The following is a description of a gene set: The cellular developmental process by which a cell establishes the intrinsic character of a cell or tissue region irreversibly committing it to a particular fate. Mouse Gene Set: GOBP_CELL_FATE_COMMITMENT species: Mus musculus, and this is the list of marker genes: Pax3, Wnt10b (NCBI Gene Id 22410), Hes5, Eya1, Elf5, Tlx1, Tbx1, Dbx1, Wnt2b, Ebf2 (early B cell factor 2), Tead3, Tgfb2, Tbx5, Runx2, Cyp26b1, Psen2, Ednra, Wnt7b, Gata1, Onecut1, Wnt9b, Dkk1, Mta1, Bmpr1a, Mga, Tox, Itgb1, Scart2, Nkx2-2, Smo, Foxa2, Ctsl (NCBI Gene Id 320361), Tbx22, Zdhhc16, Men1, Ep300, Prox1, Batf, Nr2e1, Rbbp7, Il23a, Gli3, Mir450b, Tfap4, Wnt10a, Ehmt2, Tbx18, Fgf8 (NCBI Gene Id 14179), Nkx6-2, Eomes, Lats2, Zfp157, Mtor, Nkx2-5 (NCBI Gene Id 18091), Olig1, Il7 (NCBI Gene Id 319295), Gsx1, Wnt3, Foxi3, Tbx6, Onecut2, Esrp1, Irf4, Wnt7a, Ntf3, Mef2c, Prdm1, Neurog2, Tgfb1, Spn, Pax7, Tenm4, Wnt16, Smad4, Neurog1, Gdf3, Vsx2, Tbx10, Pou4f1, Tcf7l2, Gli2 (NCBI Gene Id 98707), Sox9, Kdr, AW551984, Gap43, Wnt5b, Rhoa, Id2, Dmrt3, Gcm1, Casz1, Lbx1, Hnf1b, Wnt5a, Gata4, Epop, Cyld, Pml, Gata3, Mnx1, Smarca4, Wnt8a, Six2, Pparg, Notch2, Dock7, Foxg1, Ptf1a, Bcl2, Fzd7, Notch3, Sfrp2, Tead4, Cd69, Shh, Kdm6b, Chrdl1, Ly9, Hoxc10, Gas1, Nanog, Fgf10, Rara, Prdm11, Hes1, Il6, Fgfr2, Mitf, Tbx20, Nr2f2, Spry2, Lhx6, Ascl1, Sox6, Prrx1, Wnt9a, Gata6, Otud5, Erbb4, Smad2, Isl1, Tal1, Glis1, Cdc73, Wnt6, Gatad2a, Fkbp8, Myod1, Tm2d3, Dlx2, Wnt2, Rtf1, Tbx21, Wnt8b (wingless-type MMTV integration site family, member 8B), Neurod1, Nfia (nuclear factor I/A), Tbx15, Notch1, Nfix, Wnt11, Hey2, Olig3, Dll4, Tgfb1i1, Myt1l, Atoh7, Sfrp1, Stat6, Tnfsf18, Pou1f1, Mta2, Neurod4, Smad1, Nrg1, Ihh, Tbx4, Smarcc2, Pou3f2, Barhl2, Sox17, Brd2, Acvr1, Dlx1, Bmp4, Brd4, Nkx2-1, Smad5, Gdf7, Trp53, Ext1, Nkx2-3, Foxn1, Ets2, Pou5f1, Atoh1, Dll1, Rag2, Bmp2, Sh3pxd2b, Six1, Nodal, T, Gata5, Cdon (cell adhesion molecule-related/down-regulated by oncogenes), Sufu, Psen1, Il4, Slamf6, Spdef, Lmo4, Tbr1, Fezf2, Tgfbr1, Sox18, Sox1, Sox2, Kctd9, Nfe2l1 (NCBI Gene Id 18023), Pax6, Wnt4, Dll3, Hoxa13, Gbx1, Etv2, Prkdc, Otx2, Tlx3, Flvcr2, Tbx3, Foxp3, Chrd, Paf1, Sostdc1 (sclerostin domain containing 1), Bvht, Runx1, Epas1, Bcl11b, Wnt1, Dmrta2, Stat3, Myl2, Tunar, Gatad2b, Fgf13 (fibroblast growth factor 13), Pax2, Rbpj, Olig2, Sox8, Edn1, Foxn4, Gsc, Ctr9, Sox13, Ptch1 (NCBI Gene Id 77214), Sox5, Rab10, Nfib, Mesp1, Zfp521, Lhx3, Cdc42, Dhh, Arhgef2, Hand1, Fev, Apc2, Arx, Loxl3, Jag2, Tbx19, Hdac1, Nkx6-3, Tbx2, Foxc2, Hoxd10, Fgfr1, Isl2, Il6ra, Hdac2 (histone deacetylase 2), Mta3, Chd4, Gfi1, Foxa1 (forkhead box A1), Mbd3, Slamf8, Ntf5, Pdpn, Ctnnb1, Leo1, Hoxa11, Evx1, Lgals1, Ror2, Fgf2, Ptch2, Opa1, Hoxa2, Ntrk3, Prdm14, Wt1, Nkx6-1 (NK6 homeobox 1), Rbbp4, Tfap2c, Wnt3a, Tcf3, Gsx2, Lats1, Braf, Gata2, Pitx1, Casp3, Fgfr3, Apc